Given this list of marker genes GCNT2, IL1B, FGB, AGER (NCBI Gene Id 177), SKAP1, TNF, FLOT1, CEACAM6, BMP7, CD44, FGG, FGA, LCK (LCK proto-oncogene, Src family tyrosine kinase), IL10, here is a description of the gene set: Human Gene Set: GOBP_POSITIVE_REGULATION_OF_HETEROTYPIC_CELL_CELL_ADHESION Any process that activates or increases the frequency, rate, or extent of heterotypic cell-cell adhesion. studied in species Homo sapiens